Given this list of marker genes PMP22, BSCL2, FLNC, REEP1, GARS1, here is a description of the gene set: species: Homo sapiens Human Gene Set: HP_THENAR_MUSCLE_WEAKNESS Thenar muscle weakness